The following is a description of a gene set: Human Gene Set: GOBP_POSITIVE_REGULATION_OF_HEART_GROWTH Any process that increases the rate or extent of heart growth. Heart growth is the increase in size or mass of the heart. studied in species Homo sapiens, and this is the list of marker genes: MIR509-1, MAPK14, ZFPM2, PARP2 (poly(ADP-ribose) polymerase 2), MIR208A, ERBB4, TBX20 (T-box transcription factor 20), ACACB (NCBI Gene Id 32), TBX2, NRG1, IGF1, YAP1, GLI1, MIR19B1, BASP1, TBX5, MIR222, MIR548C, EDN1, WNT2, NOTCH1, FGFR2, RBPJ, FGF2, CDK1, CCNB1, PROX1, HEY2, FGFR1, PIM1, BMPR1A, MIR204, GATA6, WT1, MIR199A1, MEF2C, MIR19A, MIR590, AKAP6, FGF9, MIR17HG, BMP10, TGFBR3